Given this list of marker genes Glul, Otc, Rhag, Rhbg, Rhcg, Rhd, here is a description of the gene set: Any biological process involved in the maintenance of an internal steady state of ammonium. species: Mus musculus Mouse Gene Set: GOBP_AMMONIUM_HOMEOSTASIS